The following is a description of a gene set: Genes having at least one occurrence of the motif NATCACGTGAY in the regions spanning 4 kb centered on their transcription starting sites. This matches the SREBF1 transcription factor binding site V$SREBP1_01 (v7.4 TRANSFAC). Human Gene Set: SREBP1_01 studied in species Homo sapiens, and this is the list of marker genes: ZFYVE26, CCAR1, ADCY2, POLR3C, DUSP8, SDF2, NAA50, POLDIP2, HOXC5, OBI1, ZDHHC13, EME1, PRKCE, DOLK, FAM13B, TMEM258, BDNF, HOXB5, APEX1, BLNK, CD164, TRAPPC8, ARMCX6, AFF4, DIP2B, HOXA11, CANX, TRPM7, HOXA2, KLHL24, DSCAM, SNAI1, GSK3B, XPO1, U2AF2, TCEAL3, GIGYF2, RRAGC (Ras related GTP binding C), GET3, SAE1, CLN3, PICALM, GLA, TMEM199, CBX6, PHF20, KLHL28, ASIC2, CYSTM1, IGF2R (NCBI Gene Id 3482), SETD2, USH1G, GGN, OTOP2, EPC1, HSPBAP1, GPNMB, SMCR8, NSD3, LAMP1, HK2, ATF4, TOP3A, RNF181, UBE2B, MICU1, STMN1, ASPSCR1, RSPRY1, ACTMAP, SOX10, TRMO, SET, ANAPC13, STX6, ATP6V1A, USP31, LCP1, TOGARAM1, AKAP12, SEPTIN3, HNRNPH2, VPS26A, ALG1, HPS3, ARPC5, KAT7, HOXB7, CUTA, RAB3A, KAT14, OGDHL, COMMD3, SLC36A1, LNPK, TMEM156, GTF2H1, HNRNPA3, PDCD6IP, SNX16, C1orf43, DAZAP2, SUPT16H, EIF4G1, ATF7IP, GRN, IRS4, SNRPA, RGL1, DCTN4, MFSD5, TCEAL8, SIRT1, AARS1, FEN1, ATP6V0D1, HIVEP1, RRM2B, SNX2, BLOC1S1, MTCH2, BAX, SOCS2, KRTAP9-2, TCEAL7, RETREG2, TADA1, OSGEP, HOXA7, SLC35A5, ARMCX3, QTRT1, RAD9A, RNF146, KAT5, CHD2, HPS5, DVL2, ATP7A, PSME3IP1, KLF12, DLX2, FMR1, RNF115, PKN1, GNB2, PIP5K1A, CNPPD1 (NCBI Gene Id 27013), ABR, CAMK2D, EIF4B, CUL5, BEX3, ZMYND12, JOSD1, MARCHF8, SPPL3, TCEAL1, TOPORS, TUG1, MRPL27, CEP63, HOXC11, SUPT6H, SLC49A4, RAB22A (RAB22A, member RAS oncogene family), ZIC3, MCM2, ALDH6A1, UBE4B (ubiquitination factor E4B), PIAS4, NR1D1, BEX1, PPCS